Given this list of marker genes Tenm2, Dag1, Farp1, Mgll (monoglyceride lipase), Syt4, Cadm1, Gucy1a1, Fabp5, Dagla, Plcb1 (phospholipase C, beta 1), Cnr1, Abhd6, Nlgn1, here is a description of the gene set: Mouse Gene Set: GOBP_RETROGRADE_TRANS_SYNAPTIC_SIGNALING studied in species Mus musculus Cell-cell signaling from post to pre-synapse, across the synaptic cleft.